Given this list of marker genes A2m, Apob, Apoa2, Alb, Apoa1, Ubb, Lipa, Ap2a1, P4hb (NCBI Gene Id 18453), Vldlr, Apoe, Apoa4, Ces3b, Pltp, Ap2b1, Apoa5 (apolipoprotein A-V), Lmf1, Ldlr, Rps27a, Lpl, Ces3a, Apoc3, Apoc1, Angptl4, Prkaca, Apoc2, Ap2m1, Ap2s1, Apobr, Nceh1, Prkacb, Lipc, Apoc4, Npc2, Bmp1, Angptl3, Abca1, Gpihbp1 (NCBI Gene Id 68453), Pcsk5, Abcg1, here is a description of the gene set: electronically inferred by orthology from the curated human pathway This event has been computationally inferred from an event that has been demonstrated in another species.<p>The inference is based on the homology mapping from PANTHER. Briefly, reactions for which all involved PhysicalEntities (in input, output and catalyst) have a mapped orthologue/paralogue (for complexes at least 75% of components must have a mapping) are inferred to the other species. Reactome Pathway: Plasma lipoprotein assembly, remodeling, and clearance part of: Transport of small molecules species: Mus musculus